The following is a description of a gene set: Activated human macrophages and PMNs are able to produce 17-series sulfido-conjugated specialised proresolving mediators (SPMs) that are able to resolve acute inflammation and promote tissue regeneration. The ω-3 polyunsaturated fatty acid docosahexaenoic acid (DHA) is the source of these novel SPMs termed resolvin conjugates in tissue regeneration (RCTR) and protectin conjugates in tissue regeneration (PCTR). protectin conjugate in tissue regeneration PCTR and RCTR are thus named because they share proposed biosynthetic pathways, structural features, and biological actions with the DHA-derived protectins and resolvins (respectively) as well as displaying potent tissue-regenerative actions.<br><br>The proposed biosynthetic pathways for PCTRs and RCTRs are described here. Mammalian lipoxygenases insert molecular oxygen predominantly in the S-stereochemistry, so the hydroxy groups at the 7- and 17-positions are presumed to be in the S-configuration. The R-containing diastereomers of these products may also possess biological activity in the resolution of inflammation and tissue regeneration but they are not described here. part of: Biosynthesis of DHA-derived sulfido conjugates Reactome Pathway: Biosynthesis of protectin and resolvin conjugates in tissue regeneration (PCTR and RCTR) studied in species Homo sapiens, and this is the list of marker genes: LTC4S